Given this list of marker genes Sct, Tlcd4, Cndp2, Eif4enif1, Med1, Erich5, Zfp91, Slc26a1, Tmbim7, Celf5, Tmem231, Dclk1, Zfp609 (zinc finger protein 609), Ola1 (NCBI Gene Id 78355), Prob1, Ring1, Zbtb41, Dusp18, Cd160, Fundc1, Xrcc5 (NCBI Gene Id 98297), Abcb1a, Gdf11, Naa11, Trpm1, here is a description of the gene set: Genes predicted to be targets of miRBase v22 microRNA mmu_miR_9769_3p in miRDB v6.0 with MirTarget v4 prediction scores > 80 (high confidence targets). Mouse Gene Set: MIR_9769_3P from publication Chen Y, Wang X (PMID 31504780) species: Mus musculus